The following is a description of a gene set: Cylindric portion of the dendrite, directly stemming from the perikaryon, and carrying the dendritic spines. studied in species Mus musculus Mouse Gene Set: GOCC_DENDRITIC_SHAFT, and this is the list of marker genes: Kirrel3, Ntsr1, Syngap1, Gabbr1, Inpp5j, Gria1, Akap5, App, Hspa8, Hcn1, Prex1, Rtn4r, Grk2, Cnih2, Grm5, Cript, Ntsr2 (NCBI Gene Id 18217), Gria2, Drd4 (dopamine receptor D4), Dlg3, Nsf, Slc1a2, Whrn, Map1a, Drd1, Slc8a1, Zfp804a, Chrna7, Gsk3b, Hspa5, Nlgn1, Arpc2, Psen1, Cnih3, Grip1, Flna, Grm4, Gipc1, Grk3, Stau2, Sez6, Grm7, Zmynd8, Jph4, Gria3, Htr2a, Nlgn2, Gper1, Hcn2, Cacna1c, Cacna1b, Homer1, Fubp3, Map2, Kirrel1, Arhgef2, Abi3bp, Dbn1, Abi3, Ilk, Epha4, Slc1a1, Baiap2, Syndig1, Prkar2b, Exoc4, Asic1, Lzts1 (leucine zipper, putative tumor suppressor 1), Kcna4, Ctnnb1, Lpar1, Rgs7bp, Grip2, Mpp2